Given this list of marker genes Igf1, Igf2, Egf, Nfkb1, Ap2a1, Ppp1ca (protein phosphatase 1 catalytic subunit alpha), Mtor, Dyrk2, Gck, Ppp1r3f, Ppp1r3d, Ppp1cb, Cltc, Prkag3, Sorbs1, Insr, Grb10, Pask, Epm2aip1, Ppp1r3a, Ppp1r3g, Gsk3b, Ptger4, Pdgfb, Smpd3, Pth, C1qtnf2 (C1q and tumor necrosis factor related protein 2), Irs1, Ppp1r3e, Tgfb1, Enpp1, Inpp5k, Irs2, Ins2, Gfpt1, Akt2, Has2, Akt1, 1810024B03Rik, Ppp1r3b, Ppp1r3c, Ins1, Esrrb, here is a description of the gene set: studied in species Mus musculus Any process that modulates the frequency, rate or extent of the chemical reactions and pathways resulting in the formation of polysaccharides. Mouse Gene Set: GOBP_REGULATION_OF_POLYSACCHARIDE_BIOSYNTHETIC_PROCESS